Given this list of marker genes MAPK10, MAP2K7, MAPK9, MAPK8, TRAF2, ERN1, MAP3K5, here is a description of the gene set: studied in species Homo sapiens IRE1a-JNK signaling pathway. Pathway ID: N01013. Pathway type: Reference. Pathway class: nt06534 Unfolded protein response. Human Gene Set: KEGG_MEDICUS_REFERENCE_IRE1A_JNK_SIGNALING_PATHWAY Pathway Definition from KEGG: ERN1 -> TRAF2 -> MAP3K5 -> MAP2K7 -> JNK